Given this list of marker genes Stk17b, Frmd4b, Nr1h3, Fam43a, Dusp1, Chst1, Snx18, Sgk1, Npc2, Abi3, Cyth4, Atp5mc2 (NCBI Gene Id 67942), Tmem86a, Fos, Rxra, Rgs2, Stard5, Mafb, Maf, Plekhg5, here is a description of the gene set: species: Mus musculus Genes negatively differentially expressed in cell type: Macrophage upon treatment with cytokine: IL-18 in mouse lymph nodes in vivo. Cytokines mediate cell-cell communication in the immune system and represent important therapeutic targets. A myriad of studies have highlighted their central role in immune function, yet we lack a global view of the cellular responses of each immune cell type to each cytokine. To address this gap, the authors created the Immune Dictionary, a compendium of single-cell transcriptomic profiles of more than 17 immune cell types in response to each of 86 cytokines (>1,400 cytokine-cell type combinations) in mouse lymph nodes in vivo. A cytokine-centric view of the dictionary revealed that most cytokines induce highly cell-type-specific responses. For example, the inflammatory cytokine interleukin-1β induces distinct gene programmes in almost every cell type. A cell-type-centric view of the dictionary identified more than 66 cytokine-driven cellular polarization states across immune cell types, including previously uncharacterized states such as an interleukin-18-induced polyfunctional natural killer cell state. from publication Cui A, Huang T, Li S, Ma A, Pérez JL, Sander C, Keskin DB, Wu CJ, Fraenkel E, Hacohen N (PMID 38057668) Mouse Gene Set: CUI_MACROPHAGE_IL18_RESPONSE_DN